The following is a description of a gene set: Marker genes curated from the annotated cluster as represented in the Descartes Human Gene Expression During Development database. Human Gene Set: DESCARTES_MAIN_FETAL_CHROMAFFIN_CELLS species: Homo sapiens from publication Cao J, O'Day DR, Pliner HA, Kingsley PD, Deng M, Daza RM, Zager MA, Aldinger KA, Blecher-Gonen R, Zhang F, Spielmann M, Palis J, Doherty D, Steemers FJ, Glass IA, Trapnell C, Shendure J (PMID 33184181) The gene expression program underlying the specification of human cell types is of fundamental interest. The study authors generated human cell atlases of gene expression and chromatin accessibility in fetal tissues. For gene expression, the study authors applied three-level combinatorial indexing to >110 samples representing 15 organs, ultimately profiling ~4 million single cells. The study authors leveraged the literature and other atlases to identify and annotate hundreds of cell types and subtypes, both within and across tissues. Our analyses focused on organ-specific specializations of broadly distributed cell types (such as blood, endothelial, and epithelial), sites of fetal erythropoiesis (which notably included the adrenal gland), and integration with mouse developmental atlases (such as conserved specification of blood cells). These data represent a rich resource for the exploration of in vivo human gene expression in diverse tissues and cell types., and this is the list of marker genes: INSL5, LINC01732, REG4, MLN, PKIA-AS1, ASIC5, GIP, MAB21L1, CNTFR, HMX1, RN7SL516P, IL7, PHOX2A, LINC02074, ARSF, LINC01201 (NCBI Gene Id 104266960), SLC22A10, INSM2, ENSG00000251216, PTCHD1, CFAP20DC-AS1, NTRK1, MAB21L2, GALNT16, NPY